The following is a description of a gene set: Genes down-regulated in germinal center B lymphocytes: wildtype versus ZBTB7A knockout. studied in species Homo sapiens Human Gene Set: GSE28449_WT_VS_LRF_KO_GERMINAL_CENTER_BCELL_DN B cells are indispensable for humoral immunity, as they ultimately give rise to antibody-secreting plasma cells. During T cell-dependent antibody responses, naive B cells form germinal centers (GCs), a distinct histologic structure found in secondary lymphoid organs. Naive B cells become activated upon interaction with T cells and antigen presenting cells, and begin to rapidly proliferate and form the characteristic GC structure. To elucidate the overall effect of LRF loss in the GCB cell transcriptome, gene expression microarray analysis of FACS-sorted GCB cells was performed. LRF Flox/+ mb-1 Cre+ mice were used as a control to normalize the potential effects of Cre recombinase, and four RNA samples for each genotype were used for the analysis. from publication Sakurai N, Maeda M, Lee SU, Ishikawa Y, Li M, Williams JC, Wang L, Su L, Suzuki M, Saito TI, Chiba S, Casola S, Yagita H, Teruya-Feldstein J, Tsuzuki S, Bhatia R, Maeda T (PMID 21646720), and this is the list of marker genes: DEDD, KATNIP, ANKRD6, SHOX2, MAGEB2, BDH1, SRSF6, ZNF76, PI4KB (phosphatidylinositol 4-kinase beta), RGS7, STS, FBLN5, TSPAN7, PTPRZ1, IL33 (interleukin 33), OR2H1, CLUL1, KIT (KIT proto-oncogene, receptor tyrosine kinase), GLA, ABCB4, NALF1, PSMB4, CIZ1, POLE2, CDH6, CRIPTO (cripto, EGF-CFC family member), LRP10, CDK20, SERPINA7 (NCBI Gene Id 6906), TRAF6, ACKR1, TMEM106C, RBFOX2 (RNA binding fox-1 homolog 2), SOX30, FAM234B, NID2, THBS3, NDRG2, FBXO46, RAB32, ONECUT1, BICD1, LRP2, PIGHP1, NBR1 (NCBI Gene Id 9740), MOCS3, TACR3, FARP1, GPR37, NEFL, CTDNEP1, PDLIM1, PDZD2, PTENP1, GRM7, SOSTDC1, SHOX, TMEM30B, TOM1L1, UVRAG, TNPO2, HBD (hemoglobin subunit delta), POP7, WNT8B, GABARAP, CLCN4, TSC1, EIF4G3, ALDH1B1, CYC1, TPGS2, RHOC, SMIM8, TRIM44, MTERF1, HSDL2, EXTL2, RPL23, AOPEP, ANXA1, GNRH1, ACADVL, POFUT2, PPP2R3A, ELAVL1, MAGEA10, GATA6, VAC14, MYOM2, MYT1, GIGYF2, WDFY3, GATAD1, CLTA, MGAM, UBE2H, MED14, RGS14, FMO1, SNPH, TRHR, GTPBP6, CCS, PYGO1, PSMD5, FGF7, KIAA1549L, TNFRSF10D (TNF receptor superfamily member 10d), UBE3A, RABEPK, FCER1G, TMCO6, MSL1, CCND1, ENDOU, MEIS1, ROS1, PDXDC1, PELP1, PFDN4, KLRG1, RBM17, COL9A3, CXCR2, TNNI1, CD72, PAH, COX7A1, CASP2, ADAM20, ERCC8, CNOT9, FLOT1, CHRNA5, DNTT, TAP1, RBM4B, CD5L, SAR1A, NPY1R, GADD45A, CXCL1, SHANK2, EDNRA, DOK5, UNG, RELN, SMG6, CA5B, PLAAT3, GABRB3, THOC5, SIGLEC6, SLCO1A2, FUT8, TXLNGY, CDK12, TCF4, IL12B, IFT27, KLRK1, FCGR1A, SLC11A1, HOXC11, LDAF1, ATG4A, S100A12, APCS, AGT (angiotensinogen), CBX5, KCNA6, ZBTB7B, CXCL13, DCAF11 (DDB1 and CUL4 associated factor 11), ETFDH, PCLO, DSP, APOBEC3B, CCL16, BAP1, PLA2G4A, GRIA3, GNG4, HSPBP1, S100P, SMARCE1, TULP3, LCP1, REG3A, IFNA6, ZPBP, AKAP5, PRKAA2, TYR (NCBI Gene Id 7299), TPD52L1, PDE6H, MEST